The following is a description of a gene set: The chemical reactions and pathways resulting in the breakdown of steroids, compounds with a 1,2,cyclopentanoperhydrophenanthrene nucleus. species: Mus musculus Mouse Gene Set: GOBP_STEROID_CATABOLIC_PROCESS, and this is the list of marker genes: Fgf23, Cyp19a1, Srd5a1, Hsd3b7, Scarb1, Hsd11b1, Sult1e1, Akr1c18, Hsd17b11, Ugt1a7c, Srd5a2, Cyp46a1, Cyp7a1, Akr1d1, Cyp1a2, Apoe, Cyp27b1 (cytochrome P450, family 27, subfamily b, polypeptide 1), Cyp27a1, Cyp24a1, Cyp39a1, Ywhah, Spp1, Hsd17b6, Hsd17b14